The following is a description of a gene set: electronically inferred by orthology from the curated human pathway part of: MyD88 cascade initiated on plasma membrane; MyD88:MAL(TIRAP) cascade initiated on plasma membrane studied in species Mus musculus This event has been computationally inferred from an event that has been demonstrated in another species.<p>The inference is based on the homology mapping from PANTHER. Briefly, reactions for which all involved PhysicalEntities (in input, output and catalyst) have a mapped orthologue/paralogue (for complexes at least 75% of components must have a mapping) are inferred to the other species. Reactome Pathway: IRAK2 mediated activation of TAK1 complex, and this is the list of marker genes: Tab1, Ubb, Tab3, Tab2, Rps27a